Given this list of marker genes FGF23, ADIPOR1, BBS4, NR4A3, LEP, PID1, CCNA2, FGB, UGCG, SIRT1, GCK, BBS2, STAT3, LEPR, INHBB, MKKS, MT3, here is a description of the gene set: studied in species Homo sapiens Human Gene Set: GOBP_CELLULAR_RESPONSE_TO_LEPTIN_STIMULUS Any process that results in a change in state or activity of a cell (in terms of movement, secretion, enzyme production, gene expression, etc.) as a result of a leptin stimulus. Leptin is a hormone manufactured primarily in the adipocytes of white adipose tissue, and the level of circulating leptin is directly proportional to the total amount of fat in the body. It plays a key role in regulating energy intake and energy expenditure, including appetite and metabolism.